Given this list of marker genes PDCD4, PABPC4, SSX2IP, ICAM4, SNRPD1, UROD, CSF2RB, NOLC1, TXNDC17, KLF1, GLUL (glutamate-ammonia ligase), PNMT, CENPF, APOC1 (NCBI Gene Id 341), PTMA, SOX4 (NCBI Gene Id 6659), SERBP1, STAM, FLNA, B3GNT2, S100A6, FADS2, HDC, PHTF1, CDC42BPA, CYTOR, ARL4A, PDZD8, CD40LG, CD36, MYL12A, NCL, TFR2, S100A4, PNN, ITGA2B, DKC1, PKIG, HSP90AA1, TRIB2, FBXO7, LYAR, CSF1, KCNH2, ACSL4, PPP1R14A, PRKAR2B, MBD4, CCDC112, ACSM3, SLC40A1, TFRC, PLIN2, CXADR, FAM178B, ANK1, RYR3, GATA2, SIAH2, EMP3, EPOR, MINPP1, REXO2, MPC2, BCCIP, KEL, NAA38, CNRIP1, BLVRB, FECH, RAB11FIP1 (RAB11 family interacting protein 1), MIR4435-2HG, JUND, RHAG, EREG, CAT, ZEB2, EIF5B, GATA1, NECAB1, NET1, SLC2A1, HDAC7, STAT5A, EIF4G2, LDB1, SPTA1, CTNNBL1, SSB, PA2G4, MYH10, PIP4K2A, HDAC2, LMAN1, PVT1, TUBB2A, HMGN5, PARP1, PSTPIP2, KIF20B, here is a description of the gene set: from publication Zheng S, Papalexi E, Butler A, Stephenson W, Satija R (PMID 29545397) studied in species Homo sapiens Human Gene Set: ZHENG_CORD_BLOOD_C3_MEGAKARYOCYTE_ERYTHROID_PROGENITOR